The following is a description of a gene set: Human Gene Set: GOBP_HEART_TRABECULA_MORPHOGENESIS studied in species Homo sapiens The process of shaping a trabecula in the heart. A trabecula is a small, often microscopic, tissue element in the form of a small beam, strut or rod, which generally has a mechanical function. Trabecula are usually but not necessarily, composed of dense collagenous tissue., and this is the list of marker genes: SRF, FKBP1A, FHL2, MED1, EGLN1, ADGRG6, NOTCH1, RBPJ, FOXH1, BMP5, RBP4, HEG1, ADAMTS1, DLL4, NACA, SOS1, HEY2, ENG, NOG, TGFBR1, BMP10, CAV3, BMP7, NRG1, OVOL2, TGFBR3, TGFB2, BMPR1A, CHD7, TEK, UBE4B, NKX2-5, S1PR1, HEY1